Given this list of marker genes Rgs10, Hspa1b, Hspa1a, Klf6, Ripor2, Vim, Actg1, Igkc, Dnajb1, Klf2, Fos, Emb, Cd28, Cytip, Thy1, Tsc22d3, Saraf, Fxyd5, Smc6, Cd3g, here is a description of the gene set: Mouse Gene Set: CUI_T_CELL_CD4_TL1A_RESPONSE_DN studied in species Mus musculus Genes negatively differentially expressed in cell type: CD4+ T cell upon treatment with cytokine: TL1A in mouse lymph nodes in vivo. from publication Cui A, Huang T, Li S, Ma A, Pérez JL, Sander C, Keskin DB, Wu CJ, Fraenkel E, Hacohen N (PMID 38057668) Cytokines mediate cell-cell communication in the immune system and represent important therapeutic targets. A myriad of studies have highlighted their central role in immune function, yet we lack a global view of the cellular responses of each immune cell type to each cytokine. To address this gap, the authors created the Immune Dictionary, a compendium of single-cell transcriptomic profiles of more than 17 immune cell types in response to each of 86 cytokines (>1,400 cytokine-cell type combinations) in mouse lymph nodes in vivo. A cytokine-centric view of the dictionary revealed that most cytokines induce highly cell-type-specific responses. For example, the inflammatory cytokine interleukin-1β induces distinct gene programmes in almost every cell type. A cell-type-centric view of the dictionary identified more than 66 cytokine-driven cellular polarization states across immune cell types, including previously uncharacterized states such as an interleukin-18-induced polyfunctional natural killer cell state.